The following is a description of a gene set: Mouse Gene Set: GOBP_BRANCH_ELONGATION_INVOLVED_IN_MAMMARY_GLAND_DUCT_BRANCHING The developmental growth process in which a branch of a mammary gland duct elongates. studied in species Mus musculus, and this is the list of marker genes: Esr1 (estrogen receptor 1 (alpha)), Tgfb1, Med1, Wnt5a, Tfap2c, Areg